The following is a description of a gene set: Genes down-regulated after cre-lox knockout of GATA6 in airway epithelium. Epithelial organs, including the lung, are known to possess regenerative abilities through activation of endogenous stem cell populations, but the molecular pathways regulating stem cell expansion and regeneration are not well understood. Here we show that Gata6 regulates the temporal appearance and number of bronchioalveolar stem cells (BASCs) in the lung, its absence in Gata6-null lung epithelium leading to the precocious appearance of BASCs and concurrent loss in epithelial differentiation. This expansion of BASCs was the result of a pronounced increase in canonical Wnt signaling in lung epithelium upon loss of Gata6. Expression of the noncanonical Wnt receptor Fzd2 was downregulated in Gata6 mutants and increased Fzd2 or decreased beta-catenin expression rescued, in part, the lung epithelial defects in Gata6 mutants. During lung epithelial regeneration, canonical Wnt signaling was activated in the niche containing BASCs and forced activation of Wnt signaling led to a large increase in BASC numbers. Moreover, Gata6 was required for proper lung epithelial regeneration, and postnatal loss of Gata6 led to increased BASC expansion and decreased differentiation. Together, these data demonstrate that Gata6-regulated Wnt signaling controls the balance between progenitor expansion and epithelial differentiation required for both lung development and regeneration. from publication Zhang Y, Goss AM, Cohen ED, Kadzik R, Lepore JJ, Muthukumaraswamy K, Yang J, DeMayo FJ, Whitsett JA, Parmacek MS, Morrisey EE (PMID 18536717) species: Mus musculus Human Gene Set: ZHANG_GATA6_TARGETS_DN, and this is the list of marker genes: TSPAN8, MUC1, SLCO4C1, MVD, EGFR, TUBA8, CAVIN2, PCBP3, CLDN18, CAMK2B, DUSP7, BSPRY, KCNJ15, INSIG1, TRPM6, THBS3, GIPC2, LAMA3, SPOCK2, RAB27A, PHACTR1, TMOD1, SLC52A2, CHST11, TMEM108, AKAP5, SEMA3A, TSPAN11, FZD2, DHCR7, PARP3, LDLR, SOAT1, SREBF2, ADCY7, CPM, ABCA3, LAMP3, AIF1L, GALNT14 (NCBI Gene Id 79623), SLC7A7, PPID, DCBLD1, EIF5A2, ALAD, IDI1, MATN4, COL4A3, MSMO1, COL4A4, RHOF, TEKT5, FABP5, ANO1, ARHGAP45, ACKR2, CTSB, TEAD4 (NCBI Gene Id 7004), FDPS, SLCO3A1, TXNRD3, SLC35E3, RERG